The following is a description of a gene set: species: Homo sapiens from publication El Kasmi KC, Smith AM, Williams L, Neale G, Panopoulos AD, Watowich SS, Häcker H, Foxwell BM, Murray PJ (PMID 18025162) Human Gene Set: GSE9509_10MIN_VS_30MIN_LPS_STIM_IL10_KO_MACROPHAGE_DN IL-10 regulates anti-inflammatory signaling via the activation of STAT3, which in turn controls the induction of a gene expression program whose products execute inhibitory effects on pro-inflammatory mediator production. Here we show that IL-10 induces the expression of an ETS family transcriptional repressor, ETV3 and a helicase family co-repressor, SBNO2 (Strawberry notch homolog 2) in mouse and human macrophages. IL-10-mediated induction of ETV3 and SBNO2 expression was dependent upon both STAT3, and co-stimulus through the TLR pathway. We also observed that ETV3 expression was strongly induced by the STAT3 pathway induced by IL-10 but not STAT3 signaling activated by IL-6, which cannot activate the anti-inflammatory signaling pathway. ETV3 and SBNO2 specifically repressed NF-kB-mediated transcription and can physically interact. Collectively our data suggest that ETV3 and SBNO2 are components of the pathways that contribute to the downstream anti-inflammatory effects of IL-10. We compared expression profiles of macrophages isolated from IL-10 -/- mice. Macrophages were treated with either LPS or LPS plus IL-10. Treatment times were 10, 20 and 30 minutes. Genes down-regulated in macrophages with IL10 knockout treated by LPS: 10 min versus 30 min., and this is the list of marker genes: OR6A2, TFIP11, MLXIP, IQSEC1, TAPT1, SLC35D1, CKMT2, NRN1, P4HA2, SNX15 (NCBI Gene Id 29907), KIAA1671, CSH1, ADAMTS4, PI3, FAM53B, ACSS1, IGKV4-1, TNRC6C, MDM2, MPP1, APCDD1, MYOM2, ZNF862, HCP5, PITPNM2, E2F2, NPY, CAMK1D, TSSK6, EDEM1, CLIP3, PRKCH, ACSL4, NEIL1, SNX29, FCMR, HPS4, ELMOD1, ZNF75A, LCN8, RIMS3, GRIK5, NKX6-3, ZFP36L1, QRSL1, PLCG1, SESN3, SLC24A1, YPEL3, TEX13A, NAV1, GADD45A, ERG, POU2AF1, LEF1-AS1, CYGB, CHD7, UPB1, EMP2, NCLN, IDI1, C3orf52, SPATA24, APOL3, HMHB1, STK32B, HSDL1, CCNT2, SMARCA4 (NCBI Gene Id 6597), DDR1 (discoidin domain receptor tyrosine kinase 1), TUBA4A, DOK3, LGR6, MTSS1, TBC1D8B, COX4I2, GRK5, SOCS2, IGHV5-78, LARGE2, ARPP21, AK1, SPPL2B, FREY1, RNF152, CSGALNACT1 (chondroitin sulfate N-acetylgalactosaminyltransferase 1), CD24, GPR39, SPTA1, RHOB, DGKD, LRIG1, FHIT, LEF1, RYBP, SLC9A9, ISG20, CREBBP, CDCA7L, RAG1, CDK9, TTC21A (NCBI Gene Id 199223), FAM43A (NCBI Gene Id 131583), MAP3K3, CD22, COL5A1, MTG2, ESS2, TRPC1, GBP4, GFOD1, NRIP1, STAG3 (STAG3 cohesin complex component), TCL1B, LHPP, FOXR1, PSD3, INHA, VPREB3, SOCS2-AS1, ABTB1, NOTCH4, PXDN, CEMIP2, SPSB1, HRK, FADS3 (NCBI Gene Id 3995), ITGA5, KAT6A, ZCCHC10, SYNE3, CCN2 (cellular communication network factor 2), CEP135, DBN1, MT1X, PPFIBP1, SNX25, PKD2, TCF3, CMTM7, GRHL3, PPFIA4, TMPRSS2, HMCES, INO80C, SMAD1, KCNA3, KIAA2012-AS1, AOC3, KCNN3, PRSS36, PPP1R18, TCP11L2, GET4, LAPTM5, CD19, PDE10A, LINC01013, USP34, BANK1, MYLK, DTX1, TKTL1, VPREB1, KANK2 (KN motif and ankyrin repeat domains 2), USP53, AKAP12, KCNH3, TTC7A, SHANK3, ZHX2, THTPA, BTG1, DSEL, ATG9B, CD27, PAX5, ABLIM1, TP53INP1, ZNF423, RAG2, WFS1, DBH-AS1, ID3, F2RL3, FOXO1, PCGEM1, SLC44A2, CD99, C8orf44, SOD2 (superoxide dismutase 2), CD79B, IGHV7-81, SIAH2